The following is a description of a gene set: electronically inferred by orthology from the curated human pathway part of: Tandem pore domain potassium channels studied in species Mus musculus Reactome Pathway: TWIK-releated acid-sensitive K+ channel (TASK) This event has been computationally inferred from an event that has been demonstrated in another species.<p>The inference is based on the homology mapping from PANTHER. Briefly, reactions for which all involved PhysicalEntities (in input, output and catalyst) have a mapped orthologue/paralogue (for complexes at least 75% of components must have a mapping) are inferred to the other species., and this is the list of marker genes: Kcnk3